The following is a description of a gene set: Lamina lucida cleavage species: Homo sapiens Human Gene Set: HP_LAMINA_LUCIDA_CLEAVAGE The formation of bullae (blisters) with cleavage in the lamina lucida layer of the skin., and this is the list of marker genes: ITGA6, ITGB4, KRT14, LAMB3, LAMA3, LAMC2, PLEC, COL17A1, KRT5, COL7A1